Given this list of marker genes RHO, SPATA7, RGS9BP, TMEM237, CNGA1, RD3, ATP1A4, CNGB1, GUCY2F, here is a description of the gene set: Human Gene Set: GOCC_ROD_PHOTORECEPTOR_OUTER_SEGMENT species: Homo sapiens The outer segment of a vertebrate rod photoreceptor that contains sealed membrane discs that are not connected to the ciliary membrane and containing rhodopsin photoreceptor proteins.